The following is a description of a gene set: from publication Chen Y, Wang X (PMID 31504780) Genes predicted to be targets of miRBase v22 microRNA mmu_miR_449b in miRDB v6.0 with MirTarget v4 prediction scores > 80 (high confidence targets). Mouse Gene Set: MIR_449B studied in species Mus musculus, and this is the list of marker genes: Ccdc85a, Pip4p2, Abr, Atg4b, Il6ra, Cbfa2t3, Arhgap1, Coro1c, Atp2b4, Lyplal1, Calcb, Nos1, Foxj2, Ldha, Gpr22, Erc1, Dcaf7, Mex3c, Eml5, Etl4, Rmnd5a, Mtcl2, Galnt7, Gpr158, Nectin1, Mmp25, 4930544G11Rik, Fam107a, Ppp2r3a, Zfp281, Ergic1, Dpysl4, Tppp, Acsl4, Dcx, Satb2, 9930012K11Rik, Zmym4, Slc44a2, Kitl, Azin2, Tmed8 (transmembrane p24 trafficking protein 8), Fam83h, Ago4, Dgkz, Krtap16-1, Tmem164, Pogz, Mta2, Rragc, Golph3l, Vat1, Slc6a1, Rhoh, Fut9, Trank1, Shkbp1, Rfx3, Vamp2, Scml2, Lhx2, Ppp1r11, Lman1, Ing5, Nav3, E2f3, Rps6ka4, Hcn3, Kcna6 (potassium voltage-gated channel, shaker-related, subfamily, member 6), Cuedc1, Tmem79, Tmem255a (transmembrane protein 255A), Tmem45a2, Pitpnc1, Scamp4, Lzts3, Numbl, Snx12, Scn2b, Lman2l, Calcr (NCBI Gene Id 209117), Rtn4rl1, Ankrd52, Ucn2 (NCBI Gene Id 171530), Rtl4, Pip5k1a, Syt1 (NCBI Gene Id 20979), Metap1 (methionyl aminopeptidase 1), Vwa5b2, Cacna2d2, Abcd1, Pkp4, Notch1, Erp44, Zdhhc16, Vdr, Lef1, Daam1, Rras, Zfp644, Gmnc, Tgif2, Zkscan16, Slc4a7, Zfp120, Celf3, Thumpd1, Acsl1, Asic2, Ppm1b, Nrip3, Plcb1, Cntn2, Ahcyl2, Usf1, Fbxo30, Mllt3, Ttc19, Ubl4a, Ccne2, Pacs1, Slc25a27, Hspb6, Slc35g2, Brpf3 (bromodomain and PHD finger containing, 3), Mmab, Rab21, Car7, Ltbp2, Gmfb, Srpra, Arhgap26, Serpinf2, Gabra3, Hexa, Mycn, Ppargc1b, Jade2, Fut8, Htr2c, Snx15, Ddx17, Itch, Chd1, Creb3l2, Slc25a53, Csf1r, Nat8l, Arid4b, Add2 (NCBI Gene Id 72970), Tbc1d2b, Tanc2, Dixdc1, Taf5, Vcl, Bnc2, Osgin2, Tent5a, Tom1, Svop, Foxn2, Mdm4, Akap6, Sidt2, Wscd2, Ppfia1, Dgkb, Frk, Thtpa, E2f5, Strn3, Sirt1, Notch2, Casp2, Patz1 (NCBI Gene Id 80645), Zfp282, Camta1, Lgr4, Unc13c, Slc4a8, Met, Nav1, Synj1, Gpr165, Tnrc6b, Pdgfra, Pnoc, Map2k1, Fam76a (family with sequence similarity 76, member A), Tbl1xr1, Mgat4a, Mpp2 (membrane protein, palmitoylated 2 (MAGUK p55 subfamily member 2)), Polq